The following is a description of a gene set: species: Mus musculus Genes predicted to be targets of miRBase v22 microRNA mmu_miR_3112_5p in miRDB v6.0 with MirTarget v4 prediction scores > 80 (high confidence targets). from publication Chen Y, Wang X (PMID 31504780) Mouse Gene Set: MIR_3112_5P, and this is the list of marker genes: Gpc6, Cntrob, Bptf, Hace1 (HECT domain and ankyrin repeat containing, E3 ubiquitin protein ligase 1), Ncapg, Asf1b, Itgb5, Gulp1, Chmp1b2, Gorab, Ccdc148, Cenpw, Ube2w, Rapgefl1, Tmem59, Dscaml1 (DS cell adhesion molecule like 1), Prkacb, Akap7, Grik5, 2410004B18Rik, Kpna2, Myo15a, Cyp2f2, Brwd1, Slc7a12 (NCBI Gene Id 140918), Sidt2, Pex12, Ahr, Bend4, Grin3a, Wnt3a, Lamc1, Gpr180, Cbx3, Glra2, Fbxo11, Vkorc1, Neto1, Pag1, Pdia6, Adam22, Zfp697, Nepro, Casp14, Kcnk10, Prok2, Syf2 (NCBI Gene Id 68592), Cacnb4, Wee1, Fgd5, Rfx6, Kcmf1, Morc3, Rbm18, Cpeb3 (cytoplasmic polyadenylation element binding protein 3), Plag1, Or7d10, Prkg2, Gnas, Sftpb, Chd9, Ascc3, Spta1, Vasp, Asb10, Pcdhb4, Osbp2, Ebf2, Homez, Dcp1a, Slc5a8, Hoxb6, Rttn, Tmem35b, Anln, Mbd5, Meis2, Creb1, Dpyd, Smarca5, Neurod6, Lmbr1, Zfp74, Prkd1, Setd7, Tent4a, Mndal, Cnih2, Slc26a5, Abca3, Ddx25, Cdh11, Khdrbs3, Dpy19l4, Nup58, Rai14, Parp4, Runx2, Jak2, Tfap2a, Zfp563, Gatad1, Nrarp, Grik2, Cul2, Serinc5, Rwdd4a, Slitrk6, Kcnmb2, Mon1b, Gmcl1, Lama5, Zswim6, Slc4a8, Cebpb, Hif1a, Rab3c, Ythdf1 (NCBI Gene Id 70181), Gramd2b, Dach2, Smarca1, Adss1, Arid4a, Rorb, Gpatch2l, Cacnb2, Bnc1, Eml1, Lyset, Crispld2, Hnrnpa0, Nrp1, Adgrg6, A630095N17Rik, Wasf1, Rbms1, Hacd2, Slit2, Ppp1r3b, Dpys, Dock10, 4930503E14Rik, Grk3, Pde8b, Plp1, Hey2, Fam161b, Arfgef1 (ADP ribosylation factor guanine nucleotide exchange factor 1), Nktr, Fam98a, Acly